The following is a description of a gene set: from publication Chaussabel D, Semnani RT, McDowell MA, Sacks D, Sher A, Nutman TB (PMID 12663451) Human Gene Set: GSE360_CTRL_VS_L_DONOVANI_DC_UP species: Homo sapiens Genes up-regulated in untreated dendritic cells (DC) versus DCs exposed to parasite L. donovani. Monocyte-derived dendritic cells (DC) and macrophages (MΦ) generated in vitro from the same individual blood donors were exposed to five different pathogens, and gene expression profiles were assessed by microarray analysis. Responses to Mycobacterium tuberculosis and to phylogenetically distinct protozoan (Leishmania major, L. donovani, Toxoplasma gondii) and helminth (Brugia malayi) parasites were examined, each of which produces chronic infections in humans yet vary considerably in the nature of the immune responses they trigger., and this is the list of marker genes: EIF2B5, FAM8A1, ST3GAL5, XYLT1, APOC1, WDFY3, GART, P2RY14, CD14, MTCL2, LRP1, AHCYL2, AASDHPPT, HLA-DMB, LRP3, WDR1, PECAM1, NCL, SNRPA1, MED22, LILRA2, SEC14L1, SLC38A10, TNR, KAT2A, CBX5, ACTA2, EIF3H, ATP5MC1, COIL, SF3A3, KXD1, DNAJC16, SNU13, FASTK, VASH1, ABCC5, RPL14, ZBTB1, BLTP2, SORL1, PRDX2, DNAJC9, ZWINT, MCM3AP, TRAPPC8, MPP1, CPVL, RNF4, LY6G6D, EIF3K, SELENOP, NCAN, PART1, LMTK2, TAF6, ADORA3, SCGB1A1, CD1E, GTF3C2, KRT12 (keratin 12), APRT, ANKRD17, TARDBP, GPX3, SCCPDH, TRIB2, BLVRA, BAAT, LSP1, ASTN1, METAP1, GGA3, MEGF9, MED8, GNPDA1, USF2, PIP4K2B (NCBI Gene Id 8396), PHGDH, DDX28, SYMPK, ALDH1B1, CHML, CYB561D2, ALDH1A1, VAV1, PPIC, GCHFR, INPP5D, VGLL4, ITGA3, GBX2, LTA4H, RPS6KA1, FADS1, SACS, GRHPR, SH3BGRL, ACRV1, RLIG1, PHF8, PIK3CG, TOB1, AHCY, TDRD3, DPYD, ALDH5A1, VPS52, RASSF8, NDUFS2, CD1C, PDCD4, TES, ADIPOR2, TBC1D2B, CD1B, MED12, H2AZ1, PIP4K2A, EIF4EBP1, ARHGAP4, PRCP, SGMS1, NCF4, MPPE1, ARHGEF7, PCCB, LTB, PPRC1, FAM169A, CCR5, NCAPD2, DNASE2, MYO7A, PSTPIP1, CSTF1, S100A4, ZNF473, UQCRC2, PFDN5, SLC1A4, PCNA, ENC1, SLC7A7, MISP, DIAPH1, UTP14C, KYAT1, ADH1A, HINFP (NCBI Gene Id 25988), CD33, POLR2H, CD163, ANKRD26, PPBPP2, ATP2B1, ISG20L2, FAU, CDK5, SLC35D1, NASP, RNF10, VAMP8, HLA-E, ERG, RPS6KA2, SLC7A8, SH3GL1, KCNAB2, PBX3, MDC1, TTC3, AP2A2, NDUFV1, BLOC1S1, EIF4B, HSDL2, POGZ, ANP32A, HNRNPA1, C3AR1, CTDSPL, FEN1, TXNIP, PPP1R26, GLB1, CD1D, COMT, SDC3, TMF1, RXRA, MTHFR, COL15A1, CCR1, DDX39A, PLCG2, CCT3, TASOR, UBA7